Given this list of marker genes GPI, PECAM1, NFKBIE, LSP1, COL4A2, SMOX, RAB27A, NEU1, CKAP4, SERPINB2, GAL, IFI30, PRCC, LYST, SRPK1, CORO1A, GLUL, GPNMB, ELANE, S100P, CXCL8, CES1, RAB31, ASAH1, FKBP5, LYZ (lysozyme), PRKCA, APP, SPI1, CEBPA, SRGN, IL32, QSOX1, SLC29A1, ZYX, CTSD, JUNB, SRF, CYBB, PPP5C, MNDA, SLC20A1, BTG1, PRTN3, VAT1 (vesicle amine transport 1), NR2F6, SIRPA, RNASE3, here is a description of the gene set: from publication Park DJ, Vuong PT, de Vos S, Douer D, Koeffler HP (PMID 12893766) studied in species Homo sapiens Human Gene Set: PARK_APL_PATHOGENESIS_DN Acute promyelocytic leukemia (APL) is associated with chromosomal translocations involving retinoic acid receptor alpha (RAR alpha) and its fusion partners including promyelocytic leukemia (PML) and promyelocytic leukemia zinc finger (PLZF). Using oligonucleotide arrays, we examined changes in global gene expression mediated by the ectopic expression of either PML/RAR alpha (retinoid-sensitive) or PLZF/RAR alpha (retinoid-resistant) in U937 cells. Of more than genes analyzed, genes were commonly up-regulated, and genes were down-regulated by both fusion proteins suggesting their role in the APL phenotype. In our APL model, for example, TNFAIP2, TNFR2, ELF4, RAR gamma, and HoxA1 were down-regulated by both fusion proteins in the absence of retinoic acid (RA). RA strongly up-regulated these genes in PML/RAR alpha, but not in PLZF/RAR alpha expressing U937 cells. Expression studies in NB4, retinoid-resistant NB4-R2, normal human CD34+ cells, and APL patient samples strongly suggest their role in the regulation of granulocytic differentiation. Furthermore, combined treatment with tumor necrosis factor alpha (TNF alpha) and RA synergistically enhanced granulocytic differentiation in NB4 cells but not in NB4-R2 cells. Our data indicate that APL pathogenesis and retinoid-induced granulocytic differentiation of APL cells involve genes in the cell death pathway, and that cooperation between the RA and TNFalpha signaling pathways exists. Targeting both the retinoid-dependent differentiation and the cell death pathways may improve leukemic therapy, especially in retinoid-resistant acute myeloid leukemia. Genes down-regulated in U937 cells (acute promyelocytic leukemia, APL) expressing RARA fused with either PML or PLZF.